The following is a description of a gene set: Human Gene Set: GSE20715_0H_VS_6H_OZONE_TLR4_KO_LUNG_UP We previously identified toll-like receptor 4 (Tlr4) as a candidate gene responsible for ozone (O3)-induced pulmonary hyperpermeability and inflammation. The objective of this study was to determine the mechanism through which TLR4 modulates O3-induced pulmonary responses and to utilize transcriptomics to determine TLR4 effector molecules. C3H/HeJ (HeJ; Tlr4 mutant) and C3H/HeOuJ (OuJ; Tlr4 normal), mice were exposed continuously to 0.3 ppm O3 or filtered air for 6, 24, 48 or 72 hr. Affymetrix Mouse430A_MOE gene arrays were used to analyze lung homogenates from HeJ and OuJ mice followed using a bioinformatic analysis. Inflammation was assessed by bronchoalveolar lavage and molecular analysis by ELISA, immunoblotting, and transcription factor activity. TLR4 signals through both the MYD88-dependent and independent pathways in OuJ mice, which involves MAP kinase activation, NF-kappaB, AP-1, and KC. Microarray analyses identifiedTLR4 responsive genes for strain and time in OuJ versus HeJ mice (p<0.05). One significantly upregulated cluster of genes in OuJ were the heat shock proteins (Hspa1b; Hsp70), Hsp90ab1). Furthermore, O3-induced expression of HSP70 protein was increased in OuJ compared to HeJ mice following 24-48 h O3. Moreover, BAL polymorphonuclear leukocytes (PMN) and total protein were significantly reduced in response to O3 in Hspa1a/Hspa1btm1Dix (Hsp70-/-) compared to Hsp70+/+ mice (p<0.05). TLR4 signaling (MYD88-dependent), ERK1/2, AP-1 activity, and KC protein content were also significantly reduced after O3 exposure in Hsp70-/- compared to Hsp70+/+ mice (p<0.05). These studies suggest that HSP70 is involved in the regulation of O3-induced lung inflammation through the TLR4 pathway and provide evidence that HSP70 is an endogenous in vivo TLR4 ligand. from publication Bauer AK, Rondini EA, Hummel KA, Degraff LM, Walker C, Jedlicka AE, Kleeberger SR (PMID 21543283) Genes up-regulated in comparison of lung tissue from wild type mice subjected to ozone for 0 h versus that from TLR4 deficient mice subjected to ozone for 6 h. species: Homo sapiens, and this is the list of marker genes: KCNJ10, L1CAM, CHGA, FUT7, CNN3 (NCBI Gene Id 1266), MYOZ3, NUP37, GAL, SPRYD4, METRN, ACRV1, RNF19B, ACY3, MMP10, TAMM41, PDCD4, CD3D, CCNB1IP1, TEDC1, ATG7 (NCBI Gene Id 105376952), TIGD5, PMF1, GABRB2, GPHA2, SIM1, CHTF18, ZKSCAN1, TSC1, FOXF2, PTPN5, RDH13, HSD17B2 (hydroxysteroid 17-beta dehydrogenase 2), STX8, CD300A, TUBA8 (tubulin alpha 8), USP26, S100A16, MRTFB, MARCKSL1, VPS53, PLVAP, BCL2L15, RAB8B, NCAN, P3H3, SRRM4, MGAT1, GTF2H3, ASCL1, RASL11B, JARID2, SERTAD3, C4BPA, RIPPLY3, KRT1, POFUT1, KMT5C, TMEM71, SLC8A2 (NCBI Gene Id 6543), CD79A, BCS1L, FFAR2, IGFALS, CENPV, PLEKHA2, RAC2, DDR1, RPS6KB2, UBTD1, KCNH3, XPNPEP2, CD8B, RBM38, LAIR1, NSUN4, TTR, MED16, USF1, HSF1, RNF144A, STC2, NKX3-1, HEBP2, TUBB4A, MAP2, NARF, ANXA6, QRICH1, STK25, FBP2 (NCBI Gene Id 8789), LALBA, TOX, PPP1R12C, RIPK3, BBLN, SARDH, FSCN1, PLXDC1 (plexin domain containing 1), ADCY8, PPIF, C5orf47, ASPDH, POLD1, EXTL2, ZNF112, CD19, ATP1A2, ENSG00000286190 (novel protein), SPRR2F, SPATS2, RPS3, CPA1, TMEM9B, STARD6, CLN3, MYO19, PARP9, RRM2, TRIM13, SLC25A45, PTH, KCNN1, RPL35, CRIP3, KLRD1, KLHDC3, CYSLTR2, HHATL, LUM, TSHZ2, INTS7, DDX10, RHOH, ZNF213, FAM241B, CENPK, THBS4, ENOX2, CHST10, CMTM7, PRKCA, TNFRSF18, TYRO3, HOXB3, ZUP1, TENM1, LCK, EDA, DLGAP5, IL27RA, CTC1, SGCA, SLC2A9, MDH1, MAP3K11 (NCBI Gene Id 4296), CBLC, TGIF2, C19orf73 (chromosome 19 open reading frame 73), CCM2, ORC3, SLC10A1, PHTF2 (putative homeodomain transcription factor 2), NAGS, ANGPT4, DHX58, RCOR3, CKLF, SCX, PIP4K2B, CGREF1 (cell growth regulator with EF-hand domain 1), C5orf24, VAMP5, RNGTT, APOBEC1, GJB5, ABHD6, RFNG, PACSIN1, HABP2, PIK3AP1 (NCBI Gene Id 118788), S100A9, MID1, VPS18 (VPS18 core subunit of CORVET and HOPS complexes), SH3BGR, FUS, CREB3L4, ADI1, DENND1B, KLRG1 (NCBI Gene Id 10219), SCT, CRIPTO, CD3G, TEX261, SSX5, HLA-DOB, KISS1R, SKIC8, ATP11B, HLA-G, FGF21